Given this list of marker genes Nrip1, Irx3, Hk2, Thrsp, Ap3s1, Tst, Rgs2, Adipoq, Cdkn2c, Ak2, Orm1, Selenbp1, Idh3g, Aoc3, Pparg, Pla2g6, H2-T23, here is a description of the gene set: Troglitazone (TGZ), a member of the thiazolidinedione class of anti-diabetic compounds and a peroxisome proliferator activator receptor-gamma (PPAR-gamma) agonist, restores systemic insulin sensitivity and improves the full insulin resistance syndrome in vivo. The mechanisms underlying its in vivo function are not understood. Here we investigated the potential functional interaction between PPAR-gamma and NF-kappaB in adipocytes. We show that TGZ selectively blocked tumor necrosis factor-alpha-induced and NF-kappaB-dependent repression of multiple adipocyte-specific genes and induction of growth phase and other genes. This occurs without interfering with NF-kappaB expression, activation, nuclear translocation, or DNA binding and without suppressing NF-kappaB-dependent survival signals. Notably, the expressions of some tumor necrosis factor-alpha-induced genes in adipocytes were unaffected by PPAR-gamma activation. In reporter gene assays in HeLa cells, ectopic expression of PPAR-gamma abolished induction of a NF-kappaB-responsive reporter gene by the p65 subunit (RelA) of NF-kappaB, and the inhibition was further enhanced in the presence of TGZ. Conversely, overexpression of p65 inhibited induction of a PPAR-gamma-responsive reporter gene by activated PPAR-gamma in a dose-dependent manner. The inhibitory effect was independent of the presence of NF-kappaB-binding sites in the promoter region. Other NF-kappaB family members, p50 and c-Rel as well as the S276A mutant of p65, blocked PPAR-gamma-mediated gene transcription less effectively. Thus, p65 antagonizes the transcriptional regulatory activity of PPAR-gamma in adipocytes, and PPAR-gamma activation can at least partially override the inhibitory effects of p65 on the expression of key adipocyte genes. Our data suggest that inhibition of NF-kappaB activity is a mechanism by which PPAR-gamma agonists improve insulin sensitivity in vivo and that adipocyte NF-kappaB is a potential therapeutic target for obesity-linked type 2 diabetes. from publication Ruan H, Pownall HJ, Lodish HF (PMID 12732648) studied in species Mus musculus Adipocyte abundant genes down-regulated in 3T3-L1 cells (fibroblasts induced to differentiate to adipocytes) in response to troglitazone. Mouse Gene Set: RUAN_RESPONSE_TO_TROGLITAZONE_DN